The following is a description of a gene set: species: Mus musculus Renal process that modulates the force with which blood travels through the circulatory system. The process is controlled by a balance of processes that increase pressure and decrease pressure. Mouse Gene Set: GOBP_RENAL_SYSTEM_PROCESS_INVOLVED_IN_REGULATION_OF_SYSTEMIC_ARTERIAL_BLOOD_PRESSURE, and this is the list of marker genes: Hsd11b2, Emp2, Agtr1b, Ttr, F2rl1, Ednrb, Nr3c2, Cyp11b2, Cyba, Serpinf2, Pdgfb, Agt, Agtr1a, Sucnr1, Or51e2, Gja1, Adora1 (adenosine A1 receptor), Cyp2j5, Comt, Gas6, Ren1, Uts2r, Uts2, Agtr2, G6pdx, Coro2b, Mas1 (NCBI Gene Id 17171), Gja5, Ptpro, Rhoa (NCBI Gene Id 51787), Kcnn4, F2r, Mrgprd